The following is a description of a gene set: studied in species Homo sapiens Human Gene Set: HP_LARGE_CAFE_AU_LAIT_MACULES_WITH_IRREGULAR_MARGINS Large hypermelanotic macules with jagged borders. Large cafe-au-lait macules with irregular margins, and this is the list of marker genes: GNAS, CDKN1B, CDKN2B, CDKN2C, CDKN1A, MEN1